Given this list of marker genes Clcn2, Cacnb2, Scn2b, Cacna1h, Scn1b, Cacna2d1, Rangrf, Scn11a (NCBI Gene Id 24046), Cav3, Ank3, Kcnh2, Scn9a, Scn4b, Trpm4, Scn1a, Cacna1g, Hcn4, Ywhah, Scn2a, Scn3a, Cacna1d, Scn8a, Cacna1i, Scn4a, Cacna1c, Scn10a, Scn3b, Slmap, Gja5, Scn5a, Ptpn3, here is a description of the gene set: The process in which membrane potential changes in the depolarizing direction from the negative resting potential towards the positive membrane potential that will be the peak of the action potential. Mouse Gene Set: GOBP_MEMBRANE_DEPOLARIZATION_DURING_ACTION_POTENTIAL studied in species Mus musculus